Given this list of marker genes POC5, CENPJ, PPP1R35, CEP120, CCDC15, CHMP2A (charged multivesicular body protein 2A), POC1B, CEP295, VPS4B, here is a description of the gene set: Any process that modulates the frequency, rate or extent of centriole elongation. species: Homo sapiens Human Gene Set: GOBP_REGULATION_OF_CENTRIOLE_ELONGATION